The following is a description of a gene set: Human Gene Set: GOBP_POTASSIUM_ION_HOMEOSTASIS Any process involved in the maintenance of an internal steady state of potassium ions within an organism or cell. studied in species Homo sapiens, and this is the list of marker genes: WNK1, PRKACA, SLC12A3, SLC12A6, SLC12A5, ATP1A3, KLHL3 (NCBI Gene Id 26249), ATP1A1, KCNJ2, SLC12A8, ATP1B3 (NCBI Gene Id 483), UPK3A, SCNN1B, SLC12A4, ATP1B1, CYP11B2, ATP12A, KCNJ10, ATP1A4, ATP1A2, YWHAE, SLC12A9, UMOD, KCNH2, KCNA5, KCNMA1, SLC12A7, ATP4A, ATP6V1B1, KCTD7, ATP4B, SLC12A2, FXYD2, SLC12A1, ATP1B2, KCNQ1